Given this list of marker genes GBA1, COL4A2, GPC4 (NCBI Gene Id 2239), NUP210, ADAM9, VCAN, OS9, TFPI2, SEMA3C, GANAB, EGR1, ITGAV (integrin subunit alpha V), THBS1, ATP6AP2 (NCBI Gene Id 95880), CCN1, COL12A1, ANKRD1, ITGB4, DSG2, APP, here is a description of the gene set: species: Homo sapiens from publication Bang LG, Dasari VR, Kim D, Gogoi RP (PMID 30846786) Tha authors analyzed RNA sequencing data to investigate the comprehensive transcriptomic landscape of Verteporfin treated Type 1 endometrial cancer cell lines, including HEC-1-A and HEC-1-B. Human Gene Set: BANG_VERTEPORFIN_ENDOMETRIAL_CANCER_CELLS_UP Verteporfin is a porphyrinic photosensitizer clinically used for the photodynamic treatment of age-related macular degeneration. The authors previously tested the efficacy of Verteporfin in endometrial cancer cells and observed cytotoxic and anti-proliferative effects.